Given this list of marker genes FCER1G, ITGA10, ITGA1, ITGB1, GP5, COL1A2, FYN, ITGA2, GP6, GP1BA, ADAMTS13, COL1A1, GP1BB, GP9, VWF, LYN (LYN proto-oncogene, Src family tyrosine kinase), here is a description of the gene set: Human Gene Set: REACTOME_PLATELET_ADHESION_TO_EXPOSED_COLLAGEN species: Homo sapiens Platelet Adhesion to exposed collagen